The following is a description of a gene set: from publication Lian X, Yan C, Qin Y, Knox L, Li T, Du H (PMID 16127159) studied in species Mus musculus Genes up-regulated at 6 months of age in lungs from LIPA knockout mice, which display pulmonary pathology. The functional roles of neutral lipids in the lung are poorly understood. However, blocking cholesteryl ester and triglyceride metabolism in lysosomal acid lipase gene knockout mice (lal-/-) results in severe pathogenic phenotypes in the lung, including massive neutrophil infiltration, foamy macrophage accumulation, unwanted cell growth, and emphysema. To elucidate the mechanism underlining these pathologies, we performed Affymetrix GeneChip microarray analysis of 1-, 3-, and 6-month-old mice and identified aberrant gene expression that progressed with age. Among changed genes, matrix metalloproteinase (MMP)-12, apoptosis inhibitor 6 (Api-6), erythroblast transformation-specific domain (Ets) transcription factor family member Spi-C, and oncogene MafB were increased 100-, 70-, 40-, and 10-fold, respectively, in lal-/- lungs versus the wild-type lungs. The pathogenic increases of these molecules occurred primarily in alveolar type II epithelial cells. Transcriptional activities of the MMP-12 and Api-6 promoters were stimulated by Spi-C or MafB in respiratory epithelial cells. Treatment with 9-hydroxyoctadecanoic acids and ciglitazone significantly rescued lal-/- pulmonary inflammation and aberrant gene expression. In addition, both compounds as well as peroxisome proliferator-activated receptor gamma inhibited MMP-12 and Api-6 promoter activities. These data suggest that inflammation-triggered cell growth and emphysema during lysosomal acid lipase deficiency are partially caused by peroxisome proliferator-activated receptor-gamma inactivation. Human Gene Set: LIAN_LIPA_TARGETS_6M, and this is the list of marker genes: CTSB, S100A9, CD84, TNFAIP2, SLC11A1, KIF1A, CSTA, BEX1, CD68, FCGR2A, MMP12, SLC40A1, SLC15A3, SLC37A2 (NCBI Gene Id 219855), UTRN, AAR2, SLC6A2, MS4A6A, C3AR1 (complement C3a receptor 1), SLFN12, MMP13, IGSF6, PLA2G7, MYO5A, MARCO, C1QB, MSR1, HMOX1, RGS1, MMP8, MMP19, STEAP4, CAMP, ACP5, GPNMB, RP1, CLEC6A, MS4A7, FABP7, ADAM8, DNMT3A, CLEC4D, LY9, KLRB1, CLEC4E, SPIC, CFP, APOBEC1, FCGR2B, ACOD1, ATP6V0D2, IL1R2, CD244, C1QC, TREM2, LILRB1, CXCL2, DST, FCER1G, MPEG1, SNX6, C1QA, FCGR3A, XIST, MYRIP, FKBP5, PAPPA, GALC, NEU1, GDF15, MAFB, SEMA7A, ADGRE4P, TLR7, LILRA4, CD5L, CCR1, RAB7B, CLCA3P, LIPF (NCBI Gene Id 8513)